Given this list of marker genes MESP1, BMP2, NKX2-5, TRIM72, PARP2, MIR1-1, DLL1, IGF1, BMP10, CYP26B1, MIR204, DMPK, CCN3, EDN1, MYOD1, HDAC3, MYF5, YBX1, RGS4, MYLK3, SMAD4, MIR590, MYF6, BDNF, HDAC5, MIR19A, MAMSTR, LMOD3, BHLHE41, RGS2, SHH, HDAC4, PLPP7, MSX1, TGFB1, AKAP6 (A-kinase anchoring protein 6), PIEZO1, MIR19B1, RPL3L, NRG1, MTOR, HOPX, ARRB2, MIR200B, MYOCD, CEACAM5, GSK3A, YY1, MIR208A, FZD7, RBM24, PROX1, BCL2, FBXO22, G6PD, TRIM32, NOTCH1, HDAC1, FOXP1, MMP14, ATP11A, FRS2, TOMM70, CTDP1, TBX1, TMEM119, MYOG, KAT2A, CAV3, DKK1, MAPK14, RBM38, MIR499A (microRNA 499a), PI16, EZH2, SMYD1, HDAC9, PPARA, NLN, XBP1, WNT3A, ACTN3, PRKD1, MIR199B, MEF2C, BHLHA15, EFNB2, MIR206, PAK1, MIR222, MAML1, SIK1, MIR199A1, SHOX2, SOX6, BMP4, MIR133B, NACA, MIR133A1, here is a description of the gene set: Any process that modulates the frequency, rate or extent of striated muscle cell differentiation. species: Homo sapiens Human Gene Set: GOBP_REGULATION_OF_STRIATED_MUSCLE_CELL_DIFFERENTIATION